Given this list of marker genes ARMCX2, BEX1, RUNX1T1, EIF4EBP1, ANOS1, CTSA, EPYC, PIR, TMEM158, AOPEP, ATP13A3, FBXO3, HOXA2, CLN5, TWIST1, SLC31A1, VIM, RTL8A, JAG1, PAPPA, CEP170, ELOVL1, DPY19L1, GSTT2, BRIP1, MYH9, ZNF516, DNAJC6, PDGFA, ADAM19, PNMA1, KCNK1, SLC6A1, COL6A2, SS18, ETNK1, GNG10, EDNRB, PDLIM2, PDGFRL, NGRN, RRBP1, GLT8D2, FHL2, HOMER3, GIPC2, VOPP1, PIP4K2C, RAB29, CARM1, DLG5, COPZ2, SPON2, STK17A, ANXA3, NECTIN3, SLC25A4, FGF2, BHLHE40, TUBB2A, MEIS3P1, CNN3, AKR1B10, F3, MBOAT7, BHMT2, GOLPH3, DIP2C, MCFD2, FKTN, BCHE, OSTM1, TMEM100, KLF4, PTPN12, LTBP1 (NCBI Gene Id 4052), TRIM32, SFRP1, SLIT2, TVP23B, SEL1L, PGM3, MINDY3 (NCBI Gene Id 80013), DKK1, ILK, RRAS, RPS6KA2, TNFRSF10B, CREG1, TP53I3, STON1, LDOC1, PLOD3, DERL2, IGFBP5, MANSC1, FOXC1, ANG, MYO6, VCAM1, CHSY1, SMARCA1, OLFML2A (olfactomedin like 2A), LAMP2, PKD2, KLF8, TFPI2, SGPP1, SEMA4C, ME1, GFPT1, STX7, SLC25A32, DOK5, HIF1A, TMEM184B, KIAA1549L (NCBI Gene Id 25758), RPL23AP7, FADS3, ADORA2B, ANXA10, CRISPLD2, HS2ST1, C10orf88, ARHGEF12, TPST1, SLC6A8, STAG3L4, GPRC5B, CORO2B, LEPR, MAP2K1, TNFRSF12A, TXNDC9, MORF4L2, STAM2, ZNF532, RAB1A (RAB1A, member RAS oncogene family), TGFBR3, TEAD3, SLFN12, RGL1, COL4A5, PEA15, C11orf24, CALU, NPDC1, BPNT2, PRRG1, MTMR11, DZIP1, UPP1, CLCA4, RASSF9, ADCY9, EOGT, THBS1, PF4V1, PTGS1, EGR1, UNC13B, TUBB6, STK3, ATP10D, GPC4 (NCBI Gene Id 2239), ARHGAP29, BCAP29, SRPX2, CDC37L1, ALDH3A2, MOXD1, EMILIN1, NID1, LARGE1, DNAJC10, ASL, EDNRA, TMCO3, TSPAN4, ATP6AP2, CDH2, MT1F, TBC1D16, TENM4, SYNDIG1, MT1E, RPS6KC1, GRAMD2B (GRAM domain containing 2B), SLC38A6, FBXL2, CXCL6, ITGA5, ZCCHC24, FGD6, KATNBL1, NACC2 (NACC family member 2), LRRC32, RBFOX2, CREB3L1, TM6SF1, here is a description of the gene set: from publication Lee MS, Hanspers K, Barker CS, Korn AP, McCune JM (PMID 15210650) Genes down-regulated in comparison of intrathymic T progenitor cells (ITTP) versus thymic stromal cells. species: Homo sapiens Human Gene Set: GSE1460_INTRATHYMIC_T_PROGENITOR_VS_THYMIC_STROMAL_CELL_DN Subpopulations of human fetal thymocyte and circulating naïve T cells were obtained through FACS sorting, including CD3-CD4+CD8- intrathymic T progenitor cells (ITTP), CD3intCD4+CD8+ \double positive\ thymocytes (DP), CD3highCD4+CD8- \single positive\ thymocytes (SP4), CD3+CD4+CD8-CD45RA+CD62L+ naive T cells from cord blood (CB4+), and CD3+CD4+CD8-CD45RA+CD62L+ naive T cells from adult blood (AB4+).